The following is a description of a gene set: Human Gene Set: HP_LARYNGOMALACIA species: Homo sapiens Laryngomalacia is a congenital abnormality of the laryngeal cartilage in which the cartilage is floppy and prolapses over the larynx during inspiration. Laryngomalacia, and this is the list of marker genes: APC, RAF1, KCNMA1 (potassium calcium-activated channel subfamily M alpha 1, NCBI Gene Id 3778), WRN, POLR1A, ZNF699, DLK1, MEIS2, KAT6A, AHDC1, KRT5, SEMA3E, DTYMK, BRF1 (NCBI Gene Id 90137), GP1BB, POR, IDH1, UFD1, LRP4, POLR3A, HAAO, SYT1, KAT6B, NFIX, COL12A1, CTSK, FGFR2, PKDCC, LMNA, H3-3B, UBE3B, EFL1, CREBBP, LTBP4, AFF4, CACNA1C, CHD7, PPM1D, MEG3 (maternally expressed 3), RFX7, HIRA, UFC1, PSAP, SETBP1, GMNN, TBX3, SIAH1, KANSL1, KRT14, TBX1 (T-box transcription factor 1), JMJD1C, RALGAPA1, LONP1, COMT, ARVCF, HYLS1, RTL1, HSPG2, ADARB1, GALC, PRMT7, HDAC4, SOX4, NRCAM, RREB1, HNRNPR, TCTN3, ATP6V1E1, PCNT, ORC6, SOX9, RPL10, EP300, SATB2, H3-3A, ZBTB7A, SEC24C, SNIP1, ASXL3, SMAD2, KIF7, VPS13B, SCARF2, HOXD13